Given this list of marker genes Pik3ca, Csf2rb2, Il2, Shc1, Inpp5d, Pik3cb, Il2ra, Il2rg, Il5ra, Grb2, Sos1, Il5, Csf2, Pik3r3, Csf2rb, Pik3r2, Il2rb, Il3, Inppl1, Pik3r1, Jak2 (Janus kinase 2), Pik3cd, Ptpn6, here is a description of the gene set: Mouse Gene Set: REACTOME_INTERLEUKIN_RECEPTOR_SHC_SIGNALING Interleukin receptor SHC signaling species: Mus musculus